Given this list of marker genes BECN1, GPC4, ZCRB1, HAVCR1, GPC3, NRP1, CHMP2A, GPC6, FURIN, SDC4, HSPG2, TMPRSS2, PIK3R4, ACE2, GPC1, CHMP6, AGRN, UVRAG, CHMP4B (NCBI Gene Id 60501), CHMP7, MAP1LC3B, CTSL, CHMP3, SDC2, CHMP4A, PIK3C3, RB1, VHL, VCP (NCBI Gene Id 94731), GPC2, DDX5, SDC3, CHMP4C, GPC5, ISCU, CHMP2B, SDC1, here is a description of the gene set: Early SARS-CoV-2 Infection Events species: Homo sapiens Human Gene Set: REACTOME_EARLY_SARS_COV_2_INFECTION_EVENTS